The following is a description of a gene set: Any process that stops, prevents, or reduces the frequency, rate or extent of a neurophysiological process. Mouse Gene Set: GOBP_NEGATIVE_REGULATION_OF_NERVOUS_SYSTEM_PROCESS species: Mus musculus, and this is the list of marker genes: Lpin1, Ccn3, Chrnb2, Mtnr1b, Gpr35, Avpr1a, Eif2ak3, Tnfrsf21, Tmem98, Tac4, Ifng, Pten, Kcnc4, Abcb1a, Jam2, Hcrt, Cacnb3, Avp, Tnf, Cntnap2, Glra1, Mtmr2, Fig4, Ctsc, Npy2r